The following is a description of a gene set: Catalysis of the transfer of a fucosyl group to an acceptor molecule, typically another carbohydrate or a lipid. studied in species Homo sapiens Human Gene Set: GOMF_FUCOSYLTRANSFERASE_ACTIVITY, and this is the list of marker genes: FUT2, POFUT2, FUT11, FUT5, FUT6 (fucosyltransferase 6), FUT7, FUT9, FUT3, POFUT1, FUT4, FUT1, FUT10 (fucosyltransferase 10), FUT8